Given this list of marker genes HIF1A (NCBI Gene Id 3091), PSMC3, PSMA1, PSMC5, UBE2D2, VHL, EPO, UBE2D1, CREBBP, PSMC6, PSMA5 (NCBI Gene Id 5686), UBA52, PSMB4, CITED2, PSMB2 (NCBI Gene Id 5690), PSMC2, VEGFA, PSMB6, PSMD1, PSMA3, PSMD8, HIF1AN, EGLN3, EGLN2, HIF3A, CA9, EP300, PSMA4 (NCBI Gene Id 5685), PSMD13, PSMA7, PSMD6, ADRM1, LIMD1, PSMD7, PSMD3 (NCBI Gene Id 94019), PSMD14, PSMB3, PSMC1, PSMD12, PSMB5, AJUBA, PSMD2, PSMA6, PSMA2, ELOC, ARNT, WTIP, UBE2D3, PSMC4, EPAS1, ELOB, RBX1, EGLN1, SEM1, UBB, PSMD11, CUL2, RPS27A, HIGD1A, PSMB1, PSMB7, UBC, here is a description of the gene set: Cellular response to hypoxia Human Gene Set: REACTOME_CELLULAR_RESPONSE_TO_HYPOXIA species: Homo sapiens